Given this list of marker genes Pes1, Hoxa5, Clcn7, Rpl7l1, Zeb2, Crmp1, Slc17a5, Hsd11b2, Zfp780b, Ttc29, Bmpr1b, Scrn3, Zfp462, Egfl6, Kif1b, Atrn, Plxna1, Adcy1, Ghsr, Cd80, Rab9b, Tmcc1, Lurap1, Unc119b, Mpv17 (NCBI Gene Id 17527), Nphs1, Pla2g4b, Tmem178b, Tmem62, 2310022A10Rik (RIKEN cDNA 2310022A10 gene), Prmt8, Trim56, Tmem267, Zfp318, Vcf2, Cyp26b1, Angptl2 (NCBI Gene Id 99355), Foxm1, Gpr157, Dclre1c, Psme3, Zyg11b, Rab11fip1, Plxna3, Ahsa2, Kpna1, Zfp608, Ociad2, AI597479, Wdr6, Lrrc2, Otud7b, Tmod3, Luzp1, Nes, Gng4, Khnyn, Agpat1, Ankrd49, Rbm8a, Zfp248, Eaf1, Slc22a21, Usf3, Tmed5, Inhbc, Tpsb2, St8sia2, Gpr158, Alox8, Tpbg, Mfap5, Ltbp3, Nfatc1, Ccl9, Tyw1, Gde1, Kdelr2, Bcas2, Smu1, Pld3, Ptprj, Fam120b, Bloc1s2, Fbxo46, Zfp770, Rfesd, Tgm5, Kpna4, Rxra, Tspan15, 5730455P16Rik, Zfp175, Brs3, Slc4a5, Dnal1, C4bp, Prpf18, Chrna3, Mblac2, Sdc3, P2rx5 (purinergic receptor P2X, ligand-gated ion channel, 5), Kbtbd2, here is a description of the gene set: studied in species Mus musculus from publication Chen Y, Wang X (PMID 31504780) Genes predicted to be targets of miRBase v22 microRNA mmu_miR_7051_3p in miRDB v6.0 with MirTarget v4 prediction scores > 80 (high confidence targets). Mouse Gene Set: MIR_7051_3P